The following is a description of a gene set: studied in species Homo sapiens FOXO-mediated transcription Human Gene Set: REACTOME_FOXO_MEDIATED_TRANSCRIPTION, and this is the list of marker genes: PPARGC1A, KAT2B, FOXO3, CDKN1A, NFYA, TXNIP, TXN, KLF4, BBC3, SMAD4 (SMAD family member 4), YWHAB, SMAD3, IGFBP1, RBL2, STK11, DDIT3, CCNG2, HDAC1, G6PC1, PCBP4, CREBBP, INS, HDAC2, FOXO1, SIN3A, FOXO4, ABCA6, FOXO6 (NCBI Gene Id 343552), AKT1, SMAD2, YWHAG, FOXG1, CAV1, PCK1, AGRP (NCBI Gene Id 181), CAT, NFYC, EP300, CITED2, AKT3, RETN, NR3C1, GADD45A, SIRT3, NPY, CDKN1B, FASLG, BCL6 (BCL6 transcription repressor), PINK1, AKT2, PLXNA4, TRIM63, SREBF1, FBXO32, BCL2L11, BTG1, GCK (glucokinase), YWHAZ, ATXN3, SFN, NFYB, MSTN, POMC, SIRT1, YWHAQ, SOD2